The following is a description of a gene set: The directed movement of sulfate across a membrane. Mouse Gene Set: GOBP_SULFATE_TRANSMEMBRANE_TRANSPORT species: Mus musculus, and this is the list of marker genes: Slc26a2, Slc26a8, Slc26a9, Ucp2, Slc13a1, Slc26a3, Slc26a7, Slc26a10, Slc26a6, Slc26a11, Slc26a5, Slc26a4, Slc25a10, Racgap1, Slc26a1